The following is a description of a gene set: species: Mus musculus Reactome Pathway: Condensation of Prophase Chromosomes electronically inferred by orthology from the curated human pathway This event has been computationally inferred from an event that has been demonstrated in another species.<p>The inference is based on the homology mapping from PANTHER. Briefly, reactions for which all involved PhysicalEntities (in input, output and catalyst) have a mapped orthologue/paralogue (for complexes at least 75% of components must have a mapping) are inferred to the other species. part of: Mitotic Prophase, and this is the list of marker genes: H3c2, H2ac7, H4c1, H2bc11, H2ac24, H4c18, H3c7, H4c6, H2az2, H3c11, Rb1, H2ac11, H2ac10, H2ax, H3c13, H3c8, H4c17, H2ac1, H2ac20, H3f3a, H2bc12, Plk1, H4c2, H3c3, H2ac22, H2bc27, H2ac6, H3c6, H2bc8, H3c10, H4c14, H2bc3, H4c4, H2bc13, H2bc1, H3c4, H4c3, H2bc15, Ncapd3, H2ac15, H2ac19, H3c1, Ncapg2, H2ac23, Cdk1, H3c15, Ccnb1, H2ac8, H2ac13, H2ac12, H2bc9, H2bc7, H4c8, H4c12, H2ac4, H4c11, H4c9, H2bc22